The following is a description of a gene set: from publication Holleman A, Cheok MH, den Boer ML, Yang W, Veerman AJ, Kazemier KM, Pei D, Cheng C, Pui CH, Relling MV, Janka-Schaub GE, Pieters R, Evans WE (PMID 15295046) Human Gene Set: HOLLEMAN_DAUNORUBICIN_B_ALL_UP Childhood acute lymphoblastic leukemia (ALL) is curable with chemotherapy in approximately 80 percent of patients. However, the cause of treatment failure in the remaining 20 percent of patients is largely unknown. studied in species Homo sapiens Genes distinguishing daunorubicin resistant and sensitive B-lineage ALL; here - genes up-regulated in the drug resistant samples., and this is the list of marker genes: CDC37, PCDH9, EIF2B4, ATP1A1, EGR1, CHD4, LARP1, KCNN4, THBD, CNTN5